Given this list of marker genes BIRC5, CDC25A, CDC6, E2F1 (NCBI Gene Id 1869), RAF1, XIAP, RB1, SRC, CHRNA7, ARRB1, here is a description of the gene set: Pathway Definition from KEGG: (NNK,NNN) -> CHRNA7 -> ARRB1 -> SRC -> RAF1 -> RB1 // E2F1 => (BIRC5,XIAP,CDC6,CDC25A) Human Gene Set: KEGG_MEDICUS_ENV_FACTOR_NNK_NNN_TO_CHRNA7_E2F_SIGNALING_PATHWAY NNK/NNN to CHRNA7-E2F signaling pathway. Pathway ID: N01337. Pathway type: Env factor. Pathway class: nt06230 Cell cycle. species: Homo sapiens